Given this list of marker genes Paxx, Dclre1c, Xrcc6, Xrcc5 (X-ray repair complementing defective repair in Chinese hamster cells 5), Lig4, Nhej1, Prkdc, Xrcc4, here is a description of the gene set: Mouse Gene Set: GOCC_NONHOMOLOGOUS_END_JOINING_COMPLEX A protein complex that plays a role in DNA double-strand break repair via nonhomologous end joining. Such complexes typically contain a specialized DNA ligase (e.g. Lig4 in eukaryotes) and one or more proteins that bind to DNA ends. studied in species Mus musculus